Given this list of marker genes P2rx6, Atp2a1, Atp2a3, P2rx2, Trpc6, Calm1, Trpc7, Atp2b4, Atp2b3, Atp2b1, P2rx7, P2rx5, here is a description of the gene set: electronically inferred by orthology from the curated human pathway Reactome Pathway: Platelet calcium homeostasis species: Mus musculus part of: Platelet homeostasis This event has been computationally inferred from an event that has been demonstrated in another species.<p>The inference is based on the homology mapping from PANTHER. Briefly, reactions for which all involved PhysicalEntities (in input, output and catalyst) have a mapped orthologue/paralogue (for complexes at least 75% of components must have a mapping) are inferred to the other species.